The following is a description of a gene set: Any process that activates, maintains or increases the rate of ubiquitin transferase activity. species: Mus musculus Mouse Gene Set: GOBP_POSITIVE_REGULATION_OF_UBIQUITIN_PROTEIN_TRANSFERASE_ACTIVITY, and this is the list of marker genes: Stub1, Pten, Fzr1, Plk1, Cdc20, Skp1, Rps2, Trib3, Arrdc3, Trib1, Ube2srt, Cdc14b, Mastl, Trib2, Arrdc4, Ube2l3, Fbxw7, Bmi1, Ube2s, Topors, Btrc